The following is a description of a gene set: Reactome Pathway: pexidartinib-resistant FLT3 mutants part of: Drug resistance of FLT3 mutants studied in species Homo sapiens Pexidartinib is a type II tyrosine kinase inhibitor that is active against FLT3, including the quizartinib-resistant gatekeeper mutation F691L. Activating mutations at TKD aspartic acid residue 835 are resistant to pexidartinib-mediated inhibition, however.<br>, and this is the list of marker genes: FLT3